The following is a description of a gene set: Human Gene Set: HP_TALIPES_EQUINOVARUS Talipes equinovarus species: Homo sapiens Talipes equinovarus (also called clubfoot) typically has four main components: inversion and adduction of the forefoot; inversion of the heel and hindfoot; equinus (limitation of extension) of the ankle and subtalar joint; and internal rotation of the leg., and this is the list of marker genes: ADGRG6, EP300, CTBP1, POLR3A, BMPR1B, HK1, NR4A2, ABHD16A, PAICS, STX5, RAI1, KIF1A, NEDD4L, BBS12, COL1A2, FOXG1, ORC1, JMJD1C, ZIC3, VANGL1, GBE1, TCTN2, CTCF, MAP3K7, TRAIP, TP63, RBM8A, PSAT1, FBN2, DCHS1, LGI4, RIPK4 (receptor interacting serine/threonine kinase 4), TGFBR2, CANT1, NADSYN1, PLOD1, ALG3, HACD1, B9D1, MYH3, PEX1, UFD1, RBM10, GLI3, CEP55, COG1, PI4KA, REV3L, IGHMBP2, ZSWIM6, NEK8, EIF4A3, VRK1, ANK1, ADAT3, IFT74, SETBP1, GNPTAB, EIF2S3, TNNT3, CACNA1C, NPHP1, DRG1, USP8, H1-4, SNIP1, COMT, MTTP, MEGF10, TGFBR1, NECTIN1, NELFA, FXN, CHN1, SMOC1, KAT6B, SMARCA2, COL5A2, PIGG, STXBP1, SPTBN1 (NCBI Gene Id 91654), TAF8 (NCBI Gene Id 135763), MYBPC1, ALG14, JPH1, DHX16, TPM2 (tropomyosin 2), SYNE1, TAFAZZIN, ADAMTS15, TNNI2, FBLN5, PITX1, BMPER, DYNC2H1, COL3A1, BAP1, SEC24C, CTDP1, SLC35A2, ARL6, REEP1, GSC, SMS, TGFB3, PYCR1, HSPB1, BBS2, KIDINS220, GUSB, LAMA5, COL1A1, PEX26 (peroxisomal biogenesis factor 26), NDRG1, DHCR24, FGD4, PLXND1, SDCCAG8, LIFR (LIF receptor subunit alpha), CCNQ, EVC2, GPX4, IL6ST, MET, MFSD2A, B3GALT6, NDE1 (nudE neurodevelopment protein 1), WNK3, MYPN, CHRM3, TMCO1, PTRH2, TOR1A, NT5C2, FKTN, POLR3GL (RNA polymerase III subunit GL), SBF2, DSE, ECEL1, IRF6, BCOR, WDR73 (WD repeat domain 73), TBC1D23, IPO8, MKS1, SPEG, LZTFL1, ACBD6, IMPDH2, BBIP1, CHST14, TRIM2, POR, MYH8, RAP1GDS1, GDAP1 (ganglioside induced differentiation associated protein 1), LETM1, PLOD3, FUZ, SELENON, VPS33B, RAB3GAP2, EZH2, MYMK, SATB2, BICD2, COL12A1, AP4S1, OTUD6B, BIN1, MPZ, HNRNPK, SF3B4, APC2, TMTC3, CRLF1, BLTP1, BBS5, SLC26A2, GAD1, CPLX1, GCH1, SH3PXD2B, SH3TC2, ARSI, SALL4, SUZ12, SC5D, MAPK1, FILIP1, CRIPT, ENTPD1, LAMB2, MTRFR, ALG8, FHL1, ALG9, IHH, SMARCAL1, MTMR2, AP4E1, SCARF2, HBA1, FKBP10, EDEM3, KMT5B (lysine methyltransferase 5B), PIGL, AMMECR1, ERGIC1, YME1L1, TBX1, GLDN, CLCN3, WBP4, GLE1, EEF1A2, SEC31A, C12orf57, FKBP14, RYR3, WDPCP, COLQ, IFT172, ZC4H2, TRPV4, MSX1, ATP6V0A2, FIBP, CEP19, POLRMT, MCTP2, SCYL1, MYH7, ATP6V1E1, BBS10, SLC25A19, LMBRD1, BBS1, NALCN, HSPG2, AMER1, COL2A1, SOX9, CCBE1, TRIP11, COL5A1, ARHGAP31, NEK9, KDM5C, COL6A1, UBE2A, FAT4, ALDH18A1, HRAS, TWIST1, ELN, L1CAM, NSD2, COG8 (component of oligomeric golgi complex 8), FLNB, NKX3-2, HSD17B4, SNRPN, AP4M1, ZNF148, ORC6, PPP3CA, CTH (cystathionine gamma-lyase), BBS7, BBS4, HACE1, ATRX, CTNNA2, SYT1, ATAD1, SHROOM4, CHMP1A, TBX4, TGDS (TDP-glucose 4,6-dehydratase), MAP3K20, MYL2, GZF1, GPC4, MEGF8, DONSON, ITGA7, TRPM3, GAN, MYO9A, LMX1B, PIGB (phosphatidylinositol glycan anchor biosynthesis class B), TGFB2 (transforming growth factor beta 2), SAMD9, TFE3, MYL11, MAN2C1, ACTA1, RAB23, RECQL4, ERBB2, RAB11B, GLB1, DES, TSPOAP1, COASY, FLNA, AP4B1, NKAP, NFU1, CNTNAP1, ESAM, RSPO2, ATP6V1A, SNX14, TTN, SLC31A1, DYM, TAF1, DST, GTPBP2, CILK1, RYR1, MYMX, OTUD5, GDF5, PLK4, SLC6A9, PLEKHG5, TCTN3, ROBO1, PEX5, ITGA8, MFN2, ARVCF, PIEZO2, CREBBP, ALDH1A2, TTC8, EHMT1, SKI, MAN2B1, IFT27, RINT1, SMAD3, BBS9, GP1BB, PLOD2, COG4, SLC35D1, ERCC5, SCAPER, CFAP418, PEX2, GRIA2, STAC3, TWIST2, UNC80, FBXO7, LIMS2, RREB1, MKKS (MKKS centrosomal shuttling protein), TRIM32, TPM3, EBP, HYLS1, CHRNG, CCN2, COQ8A, FANCL (NCBI Gene Id 55120), RUSC2, IFIH1, SCLT1, MUSK, B3GAT3, DPYS, AHDC1, CCDC47, LMNA, BRPF1, KY, B4GALT7, ZNF699, MYT1L, HBA2, FGFRL1, EVC, CHST3, CC2D2A, GPC3, MED13L, WNT7A, TBX15, VWA1, PMP22, CHD7, NSD1, CTU2, ALG12, HIRA, PRUNE1, SNCA, CEP290, MAFB (MAF bZIP transcription factor B), TH